Given this list of marker genes Pak1, Pde4dip, Git1, Hspa1b, Ckap5, Hspa1a, Mecp2, Dctn1, here is a description of the gene set: studied in species Mus musculus Mouse Gene Set: GOBP_POSITIVE_REGULATION_OF_MICROTUBULE_NUCLEATION Any process that increases the rate, frequency or extent of microtubule nucleation. Microtubule nucleation is the 'de novo' formation of a microtubule, in which tubulin heterodimers form metastable oligomeric aggregates, some of which go on to support formation of a complete microtubule. Microtubule nucleation usually occurs from a specific site within a cell.